Given this list of marker genes IFNG, LEMD3, PTEN (phosphatase and tensin homolog), TSC1, SLC25A24, TSC2, here is a description of the gene set: Connective tissue nevi Human Gene Set: HP_CONNECTIVE_TISSUE_NEVI studied in species Homo sapiens Connective tissue nevi are hamartomas in which one or several components of the dermis is altered.